Given this list of marker genes SRMS, ALK, LCK, IGF1R, MAPK3, ABL1, NTRK1, PTK2B, NRG1, DDR1, LTK, here is a description of the gene set: Human Gene Set: GOBP_PEPTIDYL_TYROSINE_AUTOPHOSPHORYLATION The phosphorylation by a protein of one or more of its own tyrosine amino acid residues, or a tyrosine residue on an identical protein. species: Homo sapiens